Given this list of marker genes CLIC4, SLC40A1, VEZF1, GDF2, MIR200C, ETV2, MSN, COL18A1, FASN, BTG1, ID1, MIR181A2, MIR495, RAPGEF2, FOXP1, HEY2, JAG1, MIR21, NRP1, ICAM1 (intercellular adhesion molecule 1), GSTM3, RHOA, RDX, HOXA13, CSNK2B, PRKD2, RAB1A (NCBI Gene Id 5861), PECAM1, ROCK2, VCL, FOXJ2, HEG1, RBPJ, STC1, BLOC1S6, NAGLU, RAP2C, GJA5, RAP2B, TIE1, MIR199B, MIR181B1, SMAD4, CLDN3, ZDHHC21, LIPA, ADAMTS12 (NCBI Gene Id 81792), FZD1, FZD4, PLCB1, STARD13, MYD88, F2RL1, NRG1, LCN2, BARX1, ROBO4, ACVR1, S1PR3, AMOTL2, BMP4, FSTL1 (NCBI Gene Id 65385), FOXC2, RAPGEF3, APOLD1, BSG, PDE4D, CXCL10 (C-X-C motif chemokine ligand 10), GPX1, FZD2, MIR34A (NCBI Gene Id 407040), TJP3, KDR, PPP1R16B, KDM6B, CLDN1, EDN1, DLL1, FOXP3, ATOH8, PLOD3, MET, RAB1B, MIR1-1, IKBKB, NOTCH4, NOTCH1, MYADM (myeloid associated differentiation marker), SETSIP, F11R, CCM2 (NCBI Gene Id 9225), ACVRL1, TMEM100 (NCBI Gene Id 55273), TJP2, PTPRS, SCUBE1, RHOB, TNF, MIR99B, EZR, VEGFA, BMPR2, PDE2A, TNMD, NR2F2, RAP1A, MESP1, HPSE, PPP1R12A, DSG2, HAPLN2, CD34, PROC, NDP, RAPGEF6, ARHGEF26, PDPN, S1PR1, CLDN5, KRIT1, MIR150, ITGAX, EDNRA, HOXB5, CEACAM1, SOX17, ROCK1, MIR10A, S1PR2, IL1B, PDCD10, AFDN, TNFRSF1A, CD2AP (CD2 associated protein), PROX1, DLL4, MAGI1, FGF1 (fibroblast growth factor 1), RAP1B, EDF1 (NCBI Gene Id 8721), TJP1, BMP6, RAPGEF1, HEY1, ADD1 (NCBI Gene Id 118), CDH5, ZEB1 (zinc finger E-box binding homeobox 1), SOX18, MARVELD2, ACVR2B, EDNRB, CTNNB1, here is a description of the gene set: The process whose specific outcome is the progression of an endothelium over time, from its formation to the mature structure. Endothelium refers to the layer of cells lining blood vessels, lymphatics, the heart, and serous cavities, and is derived from bone marrow or mesoderm. Corneal endothelium is a special case, derived from neural crest cells. species: Homo sapiens Human Gene Set: GOBP_ENDOTHELIUM_DEVELOPMENT